The following is a description of a gene set: studied in species Homo sapiens Genes having at least one occurrence of the motif SCCAWATAWGGMNMNNNN in the regions spanning 4 kb centered on their transcription starting sites. This matches the SRF transcription factor binding site V$SRF_Q4 (v7.4 TRANSFAC). Human Gene Set: SRF_Q4, and this is the list of marker genes: HOXC5, DSTN, ESRRA, KLF6, ASPH, KIZ, RIMS1, SRF, PRDM11, KCNJ13, JUNB, SHF, KLHL3, HOXB4 (homeobox B4), RUNDC1, NPPA, GAB2, BLOC1S1, RERE, CUTA, LYRM1, MYL11, FOXE3, INSM1 (INSM transcriptional repressor 1), MAP2K6, ARHGEF17, TAF5L (TATA-box binding protein associated factor 5 like), IGF2-AS, SORT1, RAB30, TPM3, TLE3, ELAVL4, SLC4A3, ACTC1, HOXA5, FGFRL1, ZNF644, FLNA, MAPK14, MYL7, DUSP5, COL23A1, CHMP2B, DIXDC1, TADA3, RSU1, GRHL3, PDLIM5, PFN1, FGF8, FST, STX10, ANXA6, BEST3, CACNA1B, CALD1, LPP, DMD, MYL1, HOXB5, DLG2, MYLK, PPP2R3A, RASSF2, STAT5B, TNMD, IFRD1, PHF12, FOSB, VASP, AKIRIN2, FAM53C, EVA1C, ACTA1, CAVIN2, ACTB, NLGN3 (neuroligin 3), PRM1, NKX2-2, MYH11, MID1, RARB, MRGPRF, MMP14, ACTN1, CCN2, NR2F2, TMEM47, POU3F4, CHD2, KDM3A, THBS1, ACTG2, SND1, NPM3, TFAP2D, TPM1, C8orf17, MSX1, TPM2, MYO1E, KRTCAP2, PRR14L, SVIL (supervillin), DGKG, KCNK3, BNC2, SERPINH1, SERTAD4, MED13, TGIF1, KCNMB1, IER2, SRD5A2, CRH, ARPC4, MAPKAPK2, YBX3, ADGRG4 (NCBI Gene Id 139378), TLCD4, PLPP3, ATRX, NPAS2, DLL1, ZNF513, RASD2, PODN, CKM, VCL, AAMDC, PADI2, YRDC, SLC35A2, EMILIN2, SCUBE3, TMEM92, EGR4, RSF1, STAG2, SH3BGR, FGF17, ROCK2, GADD45G, CDKN1B, TRIM46 (tripartite motif containing 46), EML4 (NCBI Gene Id 54548), PPP1R12A, NR4A1, SLC25A4, NCOA6, AARSD1, EGR1, RHOJ, HOXD10, MUS81, FOXP2, MEIS2, FOXP1, MAP1A, MYL6, TAGLN, EGR2, MYL9, DVL3, ADAMTSL1, TBL1X, VGF, MCL1, SRP54, CX3CL1, TNNC1, LRRTM4, PLCB3, NR2F1, NUAK1, DCUN1D3, DDX17, IP6K1, XK, PPARG, SGK1, FOS, IL17B, CITED2, NPR3, HOXA3, PTCH1, MYO1B, CFL1, TANK, AKAP12, RBBP7, TGFB1I1, EGR3 (NCBI Gene Id 1960), PRUNE2, KRT17, G3BP2, EDN1, ELF4, AGRP, TMOD1, SCOC, CFL2, TBL1Y, MBNL1, CSRP1, EEF1B2, HTN1, KCNA1, CALN1, GRK6, PRMT3, JPH2, ABR, NPAS4 (NCBI Gene Id 266743), ITGB1BP2, H2AX, DUSP2, HERC1, ERBIN, CNN1, MAP3K20, EFHD1, GPR20, DUSP6, ZNF485, KBTBD12, TAFAZZIN, ASPA